The following is a description of a gene set: Genes up-regulated in the pancreatic cancer cell lines (AsPC1, Hs766T, MiaPaCa2, Panc1) but not in the non-neoplastic cells (HPDE) by decitabine (5-aza-2'-deoxycytidine). To identify potential targets for aberrant methylation in pancreatic cancer, we analyzed global changes in gene expression profiles of four pancreatic cancer cell lines after treatment with the demethylating agent 5-aza-2'-deoxycytidine (5Aza-dC) and/or the histone deacetylase inhibitor trichostatin A. A substantial number of genes were induced 5-fold or greater by 5Aza-dC alone (631 transcripts), trichostatin A alone (1196 transcripts), and by treatment with both agents (857 transcripts). Four hundred and seventy-five genes were markedly (>5-fold) induced after 5Aza-dC treatment in pancreatic cancer cell lines but not in a nonneoplastic pancreatic epithelial cell line. The methylation status of 11 of these genes was examined in a panel of 42 pancreatic cancers, and all 11 of these genes were aberrantly methylated in pancreatic cancer but rarely, if any, methylated in 10 normal pancreatic ductal epithelia. These genes include UCHL1 (methylated in 100% of 42 pancreatic cancers), NPTX2 (98%), SARP2 (95%), CLDN5 (93%), reprimo (86%), LHX1 (76%), WNT7A (71%), FOXE1 (69%), TJP2 (64%), CDH3 (19%), and ST14 (10%). Three of these genes (NPTX2, SARP2, and CLDN5) were selected for further analysis in a larger panel of specimens, and aberrant methylation of at least one of these three genes was detectable in 100% of 43 primary pancreatic cancers and in 18 of 24 (75%) pancreatic juice samples obtained from patients with pancreatic cancer. Thus, a substantial number of genes are induced by 5Aza-dC treatment of pancreatic cancer cells, and many of them may represent novel targets for aberrant methylation in pancreatic carcinoma. species: Homo sapiens from publication Sato N, Fukushima N, Maitra A, Matsubayashi H, Yeo CJ, Cameron JL, Hruban RH, Goggins M (PMID 12839967) Human Gene Set: SATO_SILENCED_BY_METHYLATION_IN_PANCREATIC_CANCER_1, and this is the list of marker genes: SFRP1, WNT4, DDX43, SMARCA1, DOK4, CYP1B1, TBX2, ZNF335, ESS2, BARD1, SERPINF1, GAS8-AS1, ZNF780B, ARPC4, KIF21B, LMF1, IL32, SMARCA2, ALX3, AHR, BARX1, TMEM51, NRGN, TP53I11, LHX1, SVIL (supervillin), HOXB1, MBNL3, STC1, CYP3A5, VTN, CDO1, ADAM8, ST14, GMFG, ICAM1, QPRT, SLC6A11, LHX2, CNIH3, TMEM176A, PIK3R3, ULBP2, GPER1, NFKB2, SOHLH2, XCL1, LAT, MGAT3, HBA1, TSKU, SSX5, ARHGEF4, TRIM25, QPCT, FOXO3, ZNF43, ROBO3, NPTX1 (NCBI Gene Id 4884), CD52, BNIP3, PAX6, DPEP3, CIITA, PRAF2, DEPDC5, ST6GALNAC2, TRIM36, SFTPA2, ELF5, IGF2, DNAJC6, LMTK2, PAEP, DUSP5, BMAL2, CCL11, GP6, MAGEA9, SALL1, S100A3, HADHAP1 (NCBI Gene Id 3031), HLA-G, TNFRSF10D (NCBI Gene Id 8793), ISG20, CEP162, LAMB3, PLAT, TYRO3, GAGE1, MX1, MYL10, CST2, KHDRBS3, PLEK2, PSMB8, UCHL1, CD22, SLC7A7 (solute carrier family 7 member 7), IFIT5, SNAI1, TESPA1, CHRM2, CD200, HBEGF, LHFPL6, MAOA, MICALL1, SPON1, MATN1, TJP2, TFAP2C, HPX, NR2E1, KCNJ2, CYB5R2, KRT85, LYPD3, DUSP10, NEFH, NETO2, RPL39L, GYPC, GIT2, CCL17, SNAP25, NES, MRC2, HSPA2, PHC1, PMAIP1, NOS1AP, SMAD3 (SMAD family member 3), MMP19, CDH3, MR1, CCL3, USP29, RASSF1, CAMKK2, SERPINE1, SLC7A11, PYCARD, OBP2B (NCBI Gene Id 29989), TRPV2, CHAC1, MCOLN3, COX7A1, SERPINA1, CCL22, WNT7A, S100A2, CACNA1A, MEG3, PLXNB3, AP4S1 (adaptor related protein complex 4 subunit sigma 1), IL37, APOC2, TIMP3, MAGED4B, H3C10 (NCBI Gene Id 8357), PRMT7, SSX1, PELI1 (pellino E3 ubiquitin protein ligase 1), IL1B, CEP131, IRF7, LAPTM5, ADAM28, EFEMP2, OPRK1, LRRC23, LDOC1 (LDOC1 regulator of NFKB signaling), TWIST1, SSUH2, PDE2A, GALNT6, TNNT1, L1TD1, SAA1, NPAS1, RPRM, FGFR3, CSF1, PAGE1, ODAD2, PRR15L, SOD2, CNN3, H2AC8, COPZ2, LRRC32, MIA, GDF15, PLAUR, NNAT, MAGEA2, GLDC, PDYN, COL21A1 (collagen type XXI alpha 1 chain), TMEM265, DUSP6, MAPK8IP3, TRAFD1, LRRC31, EFHD1, NPTX2, EFEMP1, WT1-AS, HSD17B1, ZCCHC24 (NCBI Gene Id 219654), NALF1, CCL19, SCARA3, HEY1, MCAM, SYT2, DIRAS3, CCL4, C3, CCNE2, DAZ1 (deleted in azoospermia 1), SPINT1, ITSN1 (intersectin 1), LXN, TAP2, LIN28A, PTX3, F11R, CPA3, CSF2, CD55, CDH8, APBB2, PML, AQP3, XAGE1B, CLDN3, H2AC11, KCTD14, LCK, OR7A10, OAS1, SPARC, NCOR2 (nuclear receptor corepressor 2), HOXA1, FOXL2, CDH17, PER1, JPH3, IL36RN, ANGPT2, NXT2, SLC12A4 (NCBI Gene Id 6560), BST2, IGFBP3, SYNJ2, ZNF213-AS1, CLSTN2, COL4A3, CDKN1C, SRPK3, B4GALT6, PRDM14, IL1R1, HERC3, TNF, APOA2, VCY, DNAJC12, NEU1, DAPK1, FSCN1, KLRK1 (NCBI Gene Id 22914), ASNS, SMPD1, RHOBTB2, SAP25, GCAT, IGHM, CLIP3, SUSD4, BIRC3, IL1RL2, ULK2, RBP4, CD180, PDK1, RNASE2CP, PHF8, HNF4A, GSTA1, KLK10 (NCBI Gene Id 5655), LDHB, SIRPB1, COL4A6, GSK3A, ATP4B, ABCC3, AVP, NLRP2, ATXN3L, TH, SAMD9, EPS8L1, ZNF165, ERCC4, SNTB1, NEDD4L, SCD, ABCB9, CLDN5, LIPC, ZNF492, SPRR3, EPB41L4A, MAGEB1, DHX58, TES, UPP1, CDA, KRT7, TACSTD2, STAG3, GRK2, PCDHGC3, HPGDS, MKRN3, SYN3, CCK, CX3CL1, NR1D1 (NCBI Gene Id 9572), PFKFB4, CLEC11A, SFN, CDKN1A, AGPAT4, POGLUT1, DEPP1, SLC4A1, RAB38, SIDT2, LTB, CRISP1, SLC9A5, ENOSF1, TBX19, HTR4, CHI3L1, JHY, ITGA7, PARVA (NCBI Gene Id 80050), PROCR, RAB31, ZHX2, TPST1, KLK12, HOXC13, HLA-B, C8G, KLHL11, B3GAT1, CST1, PGF, RCN3, PAX5, IL1RAPL2, HDC, RAB6A, IFIH1, CITED1, RAC2, CCHCR1, ANKRD26, ALOX12, LHX6, CBX8, DGCR11, UPK2, HIF3A, NGFR, CLTB (NCBI Gene Id 1212), PADI4, CRABP2, CACNA1G (calcium voltage-gated channel subunit alpha1 G), MSX1, SLC16A4, FAM182B, COL6A3, KIR2DL1, HTR1A, IFI6, DUTP1, FOXE1, DLK1, CXCL12 (NCBI Gene Id 6387), PXDN, CD74, MAGEA12, HOXA9, RGS17, CCL5 (NCBI Gene Id 8147), LGALSL, KLHL28, HYAL1, CA11, CABP1, APOBR, KLK11, PSAT1, PI4K2A, CTAG1B, LRRC36, SSX3, MRAS (NCBI Gene Id 654181), CYP2B6, CYP26B1, GAMT, STXBP2, KLHL36, PTGIR, KMT2A, IER3